Given this list of marker genes ZPR1, SERBP1, SUMO1P1, SUMO1, WRAP53 (NCBI Gene Id 55135), USPL1, CDKN2A (NCBI Gene Id 1029), SRPK2, HABP4, USP50, CELF3, AFF2, VRK1, DYRK3, NEAT1, HIPK2, ETS1, PML, here is a description of the gene set: A process that is carried out at the cellular level which results in the assembly, arrangement of constituent parts, or disassembly of any of the extra-nucleolar nuclear domains usually visualized by confocal microscopy and fluorescent antibodies to specific proteins. Human Gene Set: GOBP_NUCLEAR_BODY_ORGANIZATION studied in species Homo sapiens